Given this list of marker genes COG1 (component of oligomeric golgi complex 1), CYB5A, VCP, PSEN1, CYB5R3, TREM2, ADARB1, GRM7, ABCA7, KDM5A, AHDC1, CHMP2B, NEK1, RNU4ATAC, TMEM106B, OPHN1, CAMTA1, PSEN2, MAPT, SLITRK2, PDE6D, GRN, RNU4-2, APOE, CPA6 (NCBI Gene Id 57094), BICRA, here is a description of the gene set: Human Gene Set: HP_TEMPORAL_CORTICAL_ATROPHY Temporal cortical atrophy Atrophy of the temporal cortex. studied in species Homo sapiens